Given this list of marker genes RBCK1 (NCBI Gene Id 10616), RNF31 (NCBI Gene Id 80191), PRKN, XIAP, SHARPIN, here is a description of the gene set: Human Gene Set: GOBP_PROTEIN_LINEAR_POLYUBIQUITINATION A protein ubiquitination process in which a linear polymer of ubiquitin, formed by the amino-terminal methionine (M1) of one ubiquitin molecule and by the carboxy-terminal glycine (G76) of the next, is added to a protein. species: Homo sapiens